The following is a description of a gene set: from publication Chen Y, Wang X (PMID 31504780) Genes predicted to be targets of miRBase v22 microRNA hsa-miR-1539 in miRDB v6.0 with MirTarget v4 prediction scores > 80 (high confidence targets). Human Gene Set: MIR1539 species: Homo sapiens, and this is the list of marker genes: KCNMB4, TRIM6, DESI2, SURF6, GRHL3